The following is a description of a gene set: Cytokines mediate cell-cell communication in the immune system and represent important therapeutic targets. A myriad of studies have highlighted their central role in immune function, yet we lack a global view of the cellular responses of each immune cell type to each cytokine. To address this gap, the authors created the Immune Dictionary, a compendium of single-cell transcriptomic profiles of more than 17 immune cell types in response to each of 86 cytokines (>1,400 cytokine-cell type combinations) in mouse lymph nodes in vivo. A cytokine-centric view of the dictionary revealed that most cytokines induce highly cell-type-specific responses. For example, the inflammatory cytokine interleukin-1β induces distinct gene programmes in almost every cell type. A cell-type-centric view of the dictionary identified more than 66 cytokine-driven cellular polarization states across immune cell types, including previously uncharacterized states such as an interleukin-18-induced polyfunctional natural killer cell state. Mouse Gene Set: CUI_B_CELL_HGF_RESPONSE_UP studied in species Mus musculus from publication Cui A, Huang T, Li S, Ma A, Pérez JL, Sander C, Keskin DB, Wu CJ, Fraenkel E, Hacohen N (PMID 38057668) Genes positively differentially expressed in cell type: B cell upon treatment with cytokine: HGF in mouse lymph nodes in vivo., and this is the list of marker genes: Shisa5, Neurl3, Ndufv1, H3f3b, Ifi209, Oasl1